The following is a description of a gene set: species: Mus musculus Mouse Gene Set: HALLMARK_WNT_BETA_CATENIN_SIGNALING from publication Howe DG, Blake JA, Bradford YM, Bult CJ, Calvi BR, Engel SR, Kadin JA, Kaufman TC, Kishore R, Laulederkind SJF, Lewis SE, Moxon SAT, Richardson JE, Smith C (PMID 30224793) Mouse genes annotated to HALLMARK_WNT_BETA_CATENIN_SIGNALING based on orthology mappings provided by the Alliance Genome Consortium, and this is the list of marker genes: Dkk1, Kat2a, Ncor2, Fzd1, Frat1, Dvl2, Csnk1e, Myc, Lef1, Notch4, Ptch1, Adam17 (NCBI Gene Id 236174), Hey1, Gnai1, Tcf7, Numb, Wnt5b, Notch1, Maml1, Dkk4, Hdac5, Ccnd2, Skp2, Cul1, Axin1, Hey2, Wnt1, Nkd1, Trp53, Fzd8, Jag2, Hdac11, Ncstn, Axin2, Wnt6, Jag1, Rbpj, Hdac2, Psen2, Ppard, Dll1, Ctnnb1